Given this list of marker genes Ahi1, Mir124a-2 (NCBI Gene Id 723950), Thrb, Ush1c, Mir183, Cabp4, Mir124a-1, Gnat2, Mir182, Rorb, Hcn1, Crb2, Rp1, Dio3, Cnga3, Mir96, Thy1, Pde6c, here is a description of the gene set: Development of a cone cell, one of the sensory cells in the eye that reacts to the presence of light. Cone cells contain the photopigment iodopsin or cyanopsin and are responsible for photopic (daylight) vision. Mouse Gene Set: GOBP_RETINAL_CONE_CELL_DEVELOPMENT species: Mus musculus